Given this list of marker genes ADARB1, ADAR, here is a description of the gene set: In humans the deamination of adenosines to inosines is the most common editing event. It is particularly prevalent in the brain, where it leads to amino acid changes that affect the conductance of several ion channels. Inosines are recognized by the translation machinery as if they were guanosines.<BR>ADARs (Adenosine Deaminases Acting on RNA) modify pre-mRNA, acting as single peptides and recognize structural determinants in the RNA. To date 3 members of this deaminase family are known: ADAR 1, ADAR 2, and ADAR 3 that share a common modular domain structure. ADAR 1 and 2 contain a catalytic deaminase domain, a double-stranded RNA binding domain and exhibit RNA editing activity. ADAR1 activity is found in various mammalian tissues with the highest concentration in brain.<BR>An increasing number of mammalian genes have been found to undergo deamination by ADARs. Deamination by editing in pre-mRNAs encoding subunits of ionotropic glutamate receptors (GluRs) is another well studied example. An editing event at the Q/R site of the GluR2 (GluRB) subunit of AMPA receptors converts a Gln codon CAG to an Arg codon CIG rendering the heteromeric receptor impermeable to Ca 2+ ions. Another example is the editing of 5-HT2C subtype serotonin receptor mRNA resulting in receptor isoforms with reduced G-protein coupling efficiency.<BR>In mice, the editosomes with ADAR proteins require some cis-acting elements like an intronic 'editing-site complementary sequence (ECS)'. Although evolutionarily conserved, the actual role of ECS is not yet elucidated in humans. The editing complex can be generally represented as:<BR> studied in species Homo sapiens Reactome Pathway: mRNA Editing: A to I Conversion part of: mRNA Editing